The following is a description of a gene set: studied in species Mus musculus Mouse Gene Set: GOBP_DETECTION_OF_STIMULUS_INVOLVED_IN_SENSORY_PERCEPTION_OF_PAIN The series of events involved in the perception of pain in which a stimulus is received and converted into a molecular signal., and this is the list of marker genes: Disc1, Bace1, Lxn, Grin2b, Arrb2, Scrn3, Asic3, Itga2, Scn1a, Htr7, Nrg1, Il18 (NCBI Gene Id 16173), Ephb1 (Eph receptor B1), Grin2a, Ntsr1, Scn11a, Tmem120a (transmembrane protein 120A), Prdm12, Grm8, Cxcr4, Grin2d, Ano1, Calca, Htr2a, Trpa1, Tnf, Scn10a, Ntrk1, Tlr4 (toll-like receptor 4), Cxcl12, Fyn, Pawr, Scn9a, Phf24, Mmp24, Adora1 (NCBI Gene Id 98749), Tac4, Chrna5, Cacnb3, Trpv1, Tac1, Kcna1, Nr2f6, Comt